Given this list of marker genes Sall2, Zfp780b, Jarid2, Myef2, Prpf4b, Bhmt, St6galnac3, Elovl2, Pgm3, Mrps30, Smad3 (SMAD family member 3), Tmeff1, Zc3h15, Fbxl5, Dennd1b, Arfgap3, Pno1, Mospd1, Msi2, Zfp738, Herc1, Ube3a, Phactr4, Ednrb, Dars1, Zfp26 (zinc finger protein 26), Cpeb2, Cnnm3, Nudcd1 (NudC domain containing 1), Garnl3, Acot12 (NCBI Gene Id 74899), Chrdl1, Sgcz, Mettl8, Clec14a, Zc3h18 (zinc finger CCCH-type containing 18), Tbx20 (NCBI Gene Id 77243), Denr, Cep97, Cnot8, Rtn4, Ubp1, Zfp65, Evi5, Reps2, Bbs4, Slc7a2, Hnf4g, Angel1, Tyw3, Zmym2, Dcaf10, N4bp2l2, Dr1, Ccl4, Tube1, Iqsec3, Slc16a1, Slc7a6, Ing2, Hif1a, Elmod1, Ccdc88a, Coq2, Ankrd17, Phf6, Ctbp2, Wdfy1, Dync2i1, Osbpl9, Edem3, Trp53inp1, Repin1, Gad1, Fktn, Cherp, Grm3, Dsc2 (desmocollin 2), Esyt3, Slitrk2, Man1a2, Ctbp1, Tmco3, Kctd10, Stam, Rsbn1l, Ube3c, Nrp1, Ikzf2, 2510009E07Rik, Meis2 (Meis homeobox 2), Cfap298, Rtn1, Zfp759, Otud6b, Dcaf12l2, Zbtb39, Stx7, Epha7, Lhcgr, Phf12, Ttl, Zfp599, Kpna3, Slc7a11, Edem1, Lhx2, Cdh8, Zeb1, Klf11, Adamdec1, Cxcl5, Slc4a8, Myt1l, Slc25a32, Sh3bgrl2, Il2ra, Ppm1b, Dsc1, Zfp706 (zinc finger protein 706), Vcpip1, Gabra1, Trmt11, Synj2bp, Pnisr, Eif4ebp2, Rgs7bp, Polr1f, Smurf2, Wdr43, Mospd2, Tfrc, Dot1l, Nufip2 (nuclear FMR1 interacting protein 2), Slc12a5, Zmynd11, Sox6, Sla, Lrrfip2, Fgf12, Scaf8, Per2, Atf2, Zbtb43, Sec63, Zzef1, Gatad1, Nexmif, Slc17a2, Mb21d2, Macroh2a2, Cd34, Hectd2, Sec23b, Fli1, Setbp1 (NCBI Gene Id 93678), Lrp12, Rad51b, Kdm2a, Cul3, Fmnl2 (NCBI Gene Id 71409), Nckap1, Pgr15l, Or5b95, Pparg, Kif3b, Sox9, Cdh2, Rsf1, Zfp148, Cyp4v3, Pdcd6ip (NCBI Gene Id 97504), Adnp, Top1, Ammecr1, Kpna4, Stambpl1, Atad2b, Homer1, Mroh2a, Asah2, Rora, Tmem33, Plppr4, Plscr1, Hoxb2 (homeobox B2), Naaladl2, Lyplal1, Mfsd9 (major facilitator superfamily domain containing 9), Vav3, Dcp1a, Phf8 (NCBI Gene Id 320595), Ptpra, Zfp608, Atrx, Zfp846, Otud4, Tmc7, Nol4, Sall1, Chsy1, Zfp709, Pdlim5, Suco, Slc9a6 (NCBI Gene Id 236794), Ube2n, Elavl1, Matr3, Twf1, Cux2, Hdac8, Foxf1, Crispld1, Tab3, AI593442, here is a description of the gene set: Mouse Gene Set: MIR_7236_5P Genes predicted to be targets of miRBase v22 microRNA mmu_miR_7236_5p in miRDB v6.0 with MirTarget v4 prediction scores > 80 (high confidence targets). studied in species Mus musculus from publication Chen Y, Wang X (PMID 31504780)